Given this list of marker genes LRP12, COL19A1, CNTN3, RB1CC1, MON2, DIP2B, TUBE1, FAM200C, PPP1R3C, PDS5A (NCBI Gene Id 23244), TGFBRAP1, DCK, PABPC5, FMR1, LYRM7, ZNF681, RASEF, HDGFL3, DENND4C, ADAM22, MAP4K3, GNG2, PHF8, LYSMD3, RBM41, ZNF281, RAB3IP, MPP7, TLCD3A, CLCN4, TMEM38B, NFYB, KLHDC1, CSNK1G3, ANKRD20A2P, UBE2H, NOVA1, MPDZ, PPP1R3A, ELMO1, RANBP3, ELF1, ABCC12, RPRD1B, GLRA3, FCRL1, RASGRP1, DNAAF4, MYNN, CPEB2, C11orf58, TWF1, PYGO1, ZNF770, KCNT2, GATA3, TRIM33, FUT9, SERPINB8, PIGN, DR1, PLD5, FRMD4B, BCCIP, YAE1, MAEL, NODAL, ST6GALNAC5, ATXN7L3B, PTPN4, PRPF40A, SLC36A3, GALNT6, CPEB1 (NCBI Gene Id 64506), GABPA (NCBI Gene Id 2551), ZNF384, TUBB, FASTKD2, RSF1, SLC10A2, ENTHD1, EFHD1, TNPO1, PDZRN4, FRMD6, N4BP2, CNRIP1, STON2, S100A7A, FOXD4L3, TCEAL6, HNMT, RAP1GDS1, PLSCR1, PHC3, FMO5, SEMA5A, STEAP2, SRSF12, PDCL, HIVEP1, ZFP36L1, ACSL3, SLC25A25, SEM1, UGT2A3, MTA1 (metastasis associated 1), LRRC19, SLC7A11, VPS37A, NDUFB4, TENM1, ALX1, TRMT12 (NCBI Gene Id 55039, tRNA methyltransferase 12 homolog), PDE3A, PREPL, DACH1, NAF1 (nuclear assembly factor 1 ribonucleoprotein), LPP, TRAPPC10, SSH3, FLI1, CREBBP, CEP43, LRP2, EPAS1, VSIG1, ATF7IP2, MAP3K2, RAP1A, ZNF827, RAB3C, AFTPH, PGBD2, CLCN3, ASIC2, TRIM58, GNA11, ZNHIT6, CTSE, BOLL, MS4A12, ZSWIM3, DDX3X, DARS1, ANO6, TCERG1L, IFNA2, RNF38, PRRG4, ZNF850, PAPPA, DLX1, ADD3, CDH9, GABRA3, PCDH10, PLAUR, OTC, PALLD, OSMR, CSRNP3, ANKRD10, MARCHF5, OSBPL11, SNX12, GMDS, CPSF6, PUS7L, ATL3, DAZAP2, SRSF10, SIX1, CAB39, DRAM2, ADGRV1, C9orf72, BET1, DGKH, NPY2R (neuropeptide Y receptor Y2), GATAD1, OR2A4, PHF2, SGIP1, NETO1, FOXD4L6, ANKRD20A4P, LIN7A, WDR47, XRN1, MRPL50, SSX2IP, BRIP1, TMEM267, ZFY, CSMD1, ENTPD1, CDC5L (cell division cycle 5 like), SLC9A1, BMPR2, SNRPG, NFAT5, SENP3, PTRHD1, ANKRD20A1, NCKAP1L, MICU3, FABP2, ZXDA, USP46, PARD3B, KITLG, ZNF415, QKI, ANKRD20A3P, DLEU7, RSBN1L, CISD2, OOSP2 (NCBI Gene Id 219990), KMT2C, VAMP4, here is a description of the gene set: Human Gene Set: MIR4517 Genes predicted to be targets of miRBase v22 microRNA hsa-miR-4517 in miRDB v6.0 with MirTarget v4 prediction scores > 80 (high confidence targets). from publication Chen Y, Wang X (PMID 31504780) studied in species Homo sapiens